Given this list of marker genes Ubb, Pclaf, Poli, Pold4, Usp43, Rps27a, Rfc1, Pole, Uba7, Pcna, Pold1, Rpa1 (replication protein A1), Pole2, Polh, Pold2, Rfc3, Polk, here is a description of the gene set: This event has been computationally inferred from an event that has been demonstrated in another species.<p>The inference is based on the homology mapping from PANTHER. Briefly, reactions for which all involved PhysicalEntities (in input, output and catalyst) have a mapped orthologue/paralogue (for complexes at least 75% of components must have a mapping) are inferred to the other species. Reactome Pathway: Termination of translesion DNA synthesis electronically inferred by orthology from the curated human pathway part of: Translesion synthesis by Y family DNA polymerases bypasses lesions on DNA template studied in species Mus musculus